Given this list of marker genes TTC8, ZBTB14, PPP2R5C, STAC, TAFA2, DMAC1, CAMSAP2, SIX4, NFATC3, PPP3CB, ANP32E, C2orf88, IFT43, OGT, DYNLT3, TEF, RAD21, WDR36, HNRNPDL, PSEN2, PLD5, CGGBP1, ZFAND5, CD83, AGFG1 (ArfGAP with FG repeats 1), RAP2B, TIMM8A, DLX5, TTC17, AAK1, TSNAX, PDXDC1, C5orf47, PTPRJ, RPGR, SYNJ1, PAN3, CS, TMEM170A, RNASE4, SMAD2, SLIT2, IKZF5, BIN2 (NCBI Gene Id 51722), CREBZF, THSD7A, NUDT5, SCAI, ATP2C1, GGNBP2, LANCL3, UXS1, CIAO1, TECRL, HECTD4, CPSF7, F2R, TTLL7, LRRC18, KCTD5, FBXO38, NRXN1, KCNN2, LARP7 (NCBI Gene Id 51574), SYNE2, EPC1, VGLL3, LRRC7, PSD3, SRSF12, FRZB, UBE2D3, SCN7A, GNAO1, HIPK3, CTNNA3, PLAG1, GMPR, PURA, MREG, ZFP42, POFUT1, UNK, LUC7L3, ITCH, ARHGEF33, LIN28A, HIPK1, CYP24A1, DIO2, DNAJB14, CANX, USP42, VEPH1, DOCK9 (dedicator of cytokinesis 9), ACKR3, CADM2, DCUN1D5, PAPPA2, ATP1B3, KCNG3, IGSF3, NCOA7, TESK2, BRD1, HERPUD1, IGF2R, C6orf120 (NCBI Gene Id 387263), BRCC3, OAS3, ZNF559, TASOR, KCNA1, ZFPM2, NR4A3, TC2N, RNF138, QTRT2, BMP2, here is a description of the gene set: from publication Chen Y, Wang X (PMID 31504780) studied in species Homo sapiens Human Gene Set: MIR1264 Genes predicted to be targets of miRBase v22 microRNA hsa-miR-1264 in miRDB v6.0 with MirTarget v4 prediction scores > 80 (high confidence targets).